Given this list of marker genes Zdhhc12, Trem2, Plcg2, Kcnj8, Trim30a, Ppp2ca, Irgm1, Btk, Sirt2, Nlrp1b, Mark4, Atat1 (alpha tubulin acetyltransferase 1), Mavs, Hspa8, Nlrp1a, Tlr4, Dhx33, Ddx3x, Ifi213, Gm15441, Mapk8 (mitogen-activated protein kinase 8), Elp6, Brcc3dc, Gkn2, Ifi203-ps, Mefv, Eif2ak2, Gm12250, Irgm2, Ifi207, Zdhhc5, Gbp5, Ogt, Fbxl2, Csnk1a1, Ifi209, Usp50, Nlrc3, Gbp2, P2rx7, Brcc3, Cd36, Trim11, Cptp, Lats1, Nlrp3, Ptpn22, Trim31, Igtp, Zdhhc1, Ifi214, Nek7, Ifi206, Abhd17a, Casp4, Prkd1, Lamp2, Tlr6, Ifi203, Kcnk13, Lats2 (NCBI Gene Id 50523), Nlrp6, Ifi208, Mndal, Stmp1, Myd88, Pycard, here is a description of the gene set: Mouse Gene Set: GOBP_INFLAMMASOME_MEDIATED_SIGNALING_PATHWAY species: Mus musculus An intracellular signal transduction pathway that starts with a ligand binding to a pattern recognition receptor (PRR), assembly of the inflammasome complex, leading to the activation of CASP1 and inducing an inflammatory response. In some cases, inflammasome-mediated signal transduction can lead to programmed cell death, such as pyroptosis.